The following is a description of a gene set: species: Homo sapiens Human Gene Set: GOBP_CAMP_CATABOLIC_PROCESS The chemical reactions and pathways resulting in the breakdown of the nucleotide cAMP (cyclic AMP, adenosine 3',5'-cyclophosphate)., and this is the list of marker genes: PDE10A, PDE7B (phosphodiesterase 7B), PDE4C (phosphodiesterase 4C), PDE7A, PDE4A, PDE8B, PDE8A, PDE4B, PDE4D